Given this list of marker genes GJB6, STS, EDAR, CLDN10, MADD, FAM111B, SULT2B1, OTX2, TGM1, COG6, COQ2, ERCC8, POLA1, SLC13A5, ALOXE3, PRDM12, SDR9C7, TRIP4, HESX1, STIM1, TRAF6, GJB2, PROKR2, TSPEAR, GHR, ALX4, ZFHX2, CSTB, NFKBIA, LIFR, KRT14, ERCC4, PKP1, CASK, COL11A1, SOX10, CRLF1, MBTPS2, FLG, ABCA12, ARX, ELP1, ALOX12B, CTNS, ROGDI, LMNB1, RIPK4, CERS3, GLA, TP63, IKBKG, EDARADD, ARNT2, KDF1, HEXB, SOX2, PNPLA1 (NCBI Gene Id 285848), KCTD1, SOX3, SCN9A, ADAT3, NECTIN1, WNT10A, SMARCAD1, CST6, ERCC6, EDA, EDA2R, ST14, SHANK3, FGFR1, NIPAL4, CLCF1, GMPPA, ELOVL4, here is a description of the gene set: studied in species Homo sapiens Human Gene Set: HP_HYPOHIDROSIS Abnormally diminished capacity to sweat. Hypohidrosis